The following is a description of a gene set: species: Homo sapiens The chemical reactions and pathways resulting in the breakdown of a nucleoside diphosphate, a compound consisting of a nucleobase linked to a deoxyribose or ribose sugar esterified with diphosphate on the sugar. Human Gene Set: GOBP_NUCLEOSIDE_DIPHOSPHATE_CATABOLIC_PROCESS, and this is the list of marker genes: IGF1, FOXK2, ENTPD1, NUDT18, IFNG, HK1 (NCBI Gene Id 59333), ACTN3, PRKAG1, ENTPD4, ENTPD8, PFKFB1, EP300, NUDT9, PRKAG2, TPI1, NT5E, ENTPD3, FBP1, ALDOB, KAT2B, LIPA, P2RX7, STAT3, SRC, PPP2CA, COL6A1, ENTPD2, UCHL1, BPGM, INS, HTR2A, ZBTB20, CBFA2T3, PFKL, ENO3, GIT1, TIGAR, PFKP, ENO1, GALK1, GAPDH, HKDC1, PFKFB3, PKLR, OGT, ALDOA, PKM, APP, NUDT5, PGAM1, NCOR1, SLC2A6, ENTPD5, ENO4, SLC4A4, MTOR, PGAM2, TREX1, EIF6, OGDH, ENO2, ARL2, GPD1, PRXL2C, PSEN1, MLXIPL, FOXK1, BCL2L13, PRKAA2, ALDOC, DHTKD1, PGK2, PRKAG3, PRKACA, HIF1A, ZBTB7A, ADPGK, RPTOR, MTCH2, ARNT, FLCN, MLST8, GCK, PGM1, MFSD8, OGDHL, PGK1, HK2, DDIT4, PRKAA1, GAPDHS, LDHA, FKRP, SLC4A1, TRIM63, SIRT6, INSR, JMJD8, PPARA, IER3, PFKM, PGAM4, HK3, GPI, HDAC4, UCP2, PFKFB2, ENTPD7, NUPR1